Given this list of marker genes ATP1B4, C1orf21, GEMIN5, ZMYND11, RBM12, CCDC88A, CHD4 (chromodomain helicase DNA binding protein 4), JARID2, MCM9, CXCL6, TIPARP (TCDD inducible poly(ADP-ribose) polymerase), PLEKHJ1, PELI2, TEF, INPP4A, FBXO33, PRPF40A, PRKG1, PPP1R14C, GFM1, SETD7, ABTB2, C2CD2, WNK3, TNFRSF11B, PCYOX1, SENP5, CNOT2, MOB1B, ZCCHC14, CBX6, MAP10, DMD, PARP11, STYX, SMG7 (NCBI Gene Id 9887), PRKACB, MANSC1, C11orf58, RIC1, MYO16, GAB1, RTF1, CERS3, SLC25A36, PUM2, ZNF704, NMNAT3, MED14, MLLT3, VCF2, TEAD3, LIMCH1, FYB2, PPP2R1B, RBBP4, SNX2, LRRC37B, NRAS, CDK14, SMARCE1, TOX, KRTAP3-2, E2F6, SMOC1, ZEB2 (NCBI Gene Id 9839), EID2, MYCBP, AP1AR, ZFHX4 (zinc finger homeobox 4), RGS7BP, ABI2, KIAA0319, TMEM131, CCNA2, RGMB, GAN, PAWR, C1QTNF9, ANKRA2, PPP1R12A, ARFGEF3, AJUBA, MPRIP, RORA, USP46, NAA35, HIRA, NRCAM, RETREG2, CBLL1, SLC25A21, FOXO1, TMEM167A (NCBI Gene Id 153339), JMY, PIP5K1A, ZNF217, GPRC5B (G protein-coupled receptor class C group 5 member B), SETD2, ANGEL2, GSE1, USP3, NUAK1, FHIP1A, IGFBP5, EPB41L3, MGARP, PJA1, IKZF1, GLIPR1, TNFSF11, LDLRAD1, MITF, LRATD1, SENP3, NUMB, CHRM3, TBX3, COBLL1, POU2AF1 (POU class 2 homeobox associating factor 1), TAPT1, DACH1, GABRB1, FUBP3 (NCBI Gene Id 8939), WTAP, GPR82, DNMT3B, RMI1, DCUN1D4, RPS20, PCLO, ZNF700, ASCL1, FOXN3, PCBP2, UBL3, FBXO41, KRCC1 (lysine rich coiled-coil 1), RETSAT, CTNNA3, LSM11, SENP6, ERO1B, MAPK8, CDS2, ACER2, MAST4, CNTN5, SOHLH2, PPARA, TM4SF20, ING3, MTCL2, MPC1, PRKD3, RNF182, PAPSS1, WNT5A, NUDT21, HIPK1, CHIC1, ZDHHC22, PALM2AKAP2, TBC1D8B, SUSD4, ZBTB43, CADM2, PDZD8, PPP1R1C, BTF3L4, MTERF4, HOXB7, MYEF2, SDR16C5, EPHA5, BACH2 (NCBI Gene Id 653980), ARL8B, EXTL2, SLC16A7, KCNB1, CHN2, ZDHHC21, PTBP3, GRM6, NBN, FUNDC2, TM9SF3, TAF7L, CNOT7, ARAP3, ATG4C, CNOT9, MSL3, SSB, TMEM87A, DDX6, EIF5A, RASA2, ZMYM2, SH3RF1, PPP4R1, TMEM63B, IRF6, PIM2, RFX5, TMCO3, BIRC6, NR3C1, SKIL, CYLD, JADE2, KMT2A, ZBTB10, CALCRL, RNF185, PELI1, LDLRAD3, C18orf54, PNN, ARID1A, NAV1, CMPK2, ZCCHC2, SP3, PARD6G, EPN2, KLHL15, SORBS2, RPE65, ZNF830, TENM1 (NCBI Gene Id 10405), SNRK (NCBI Gene Id 87229), SUFU, KLHDC10, NIN, MYCT1, OSGEP, BIRC5, AAK1, AKAP11, UGDH, TRAPPC13, BAHCC1, RIOK1, YWHAE, PGRMC1, ITPRID2, TNRC6B, TBR1, DISC1, CSNK2B, KLHL26, AFG3L2, PPP3R1, C1QTNF9B, AEBP2, BRWD1, KLHDC2, CCND2, FZD3, IRX2, ZNF385C, TMEM263, KLHL20, CLOCK, GRM5, NAALADL2, SCAI, TFAP2C, RPS6KA6, ANKRD28, ZMAT3, ABHD17B, RUNX2, NRIP3 (nuclear receptor interacting protein 3), RICTOR, ROBO1, IL1RAP (NCBI Gene Id 3556), FBN2, OTUD1 (NCBI Gene Id 220213), ZIC4, CIPC, HDAC9, RFX3 (regulatory factor X3), KDM2A, TSTD2, EID1, NUDT10, PABPC4, ACBD3, ONECUT2, DDHD2, TLR2, DNAJB14, FBXL3, SEPTIN2, SSH1, AGTPBP1, BMPR1A, RASSF3 (Ras association domain family member 3), HOXC8, CDC14B, MAL2, GRPEL2, SLC36A3, LAMP2, DPY19L1, ARHGAP32, TLCD4, HEG1, IGFBP7, AGTR2, TMEM170B, PREX2, PAPOLG, JUND, ETV5, BNC2, HIPK2, PLCB1, KLHL28, AK1, FAM210B, SERBP1, OSBPL11, CBX5, GNB2, ATM, TBC1D23, SMARCC1, CTDSPL2, FNBP1L, AGO2, WDR43, KIF1B, YWHAZ, NEXMIF, WWC2, GUCY1A2, TRMT10A, PIM1, CITED2, TMEM33, PDS5A, CREBBP, CDYL2, TMX3, ZNF44, DLX3, NEK1, CCDC102A, MBNL2, MAMLD1, RGMA, ATAD1, UBR2, PIAS1, REEP3, UNC5D, NDUFAF4, FAM171B, MSANTD3, TMEM209, IDE, RCOR3 (NCBI Gene Id 55758), FAM169A, TBCEL, TASOR2, VAPA, KIAA0586, CBFB, BMP1, PRKAR2B, ABCD3, JAG1, MIER3, MOB4, RNF169, NIPBL, ERI1, NCAM2, PMS2, NCBP3, LARP4, UBE2D2 (ubiquitin conjugating enzyme E2 D2), GLCE, WASF3, SGIP1, ERBB4, CRISPLD1, ANKRD17, LMNA, OGT, EBPL, HNRNPA3, ARL5A, FAM168A, MBTD1 (NCBI Gene Id 54799), UBE2G1, CHSY1, ELOC, GTF3C4, HSPA14, COG6, MAP4K3, LTN1, ARHGAP28, MFSD14B, AFF4, PRDM1, GPR180, AGPAT1, TIMP3, SASH1, CARF, LCLAT1, CLDN8, MIB1, ZBTB39, USP24, KIF26A, MACF1, FAM222B, RPS6KA2, DDX17, ZNF512, FAM124B, TERF1 (telomeric repeat binding factor 1), C6orf62, WDR89, FGD4, TAX1BP1, RNFT1, RUNDC3B, KRAS, MARCHF1, GLIS1, RBMS3, ERMP1, LRRC47, ARMH4, CPSF6, SEMA6A, RBM46, CTTN, PBX1, RABGAP1, VASP, GABRG1, MAP3K2, SETBP1, HSPE1-MOB4 (HSPE1-MOB4 readthrough), BBS12, ZNF805, TNRC6C, GABPA, USP38, PTPN11 (protein tyrosine phosphatase non-receptor type 11), KLF11, GABRA4, YPEL1, TTC28, MBNL1, ZFAND5, TP53BP1, ELN, MDM4, POC1B-GALNT4, C5orf24, CPNE4, ZBTB34, KMT2C, SOX21, CSNK2A1, GALK2 (NCBI Gene Id 2585), GRIK3, CDC42BPA, SMC6, HTATSF1, NUFIP2, SMAD5, EPHA7, TWSG1, SWAP70, SORCS3, MET (NCBI Gene Id 4233), PNISR, GALNT4, BEND4, SGO2, TBL1XR1, RET, PGM2L1, PAPOLA, RAB33B, MED1, DIS3L2, PTPRZ1, PSD3, CDK12, SAMD8, EIF4E3, TMEM106B, ZBTB21, PPARGC1A, KDM7A, OPRM1, TRPC3, ZNF706 (zinc finger protein 706), SAMD13, TMED10, RB1CC1, ATP6V0A2, DPP10, RNF38, RAG1, CCR1, SLC39A14, DCBLD2, HS2ST1, DDX5, NCL, SYNCRIP, BTBD10, TTC14, FBXO22, CYCS, RIMS2, STK38L, KAT2B, ZC3H12C (zinc finger CCCH-type containing 12C), ZBTB20, FOXN2, TMEM161B, CDK17, ELMOD2, CREB1, ATP2B4, RPS3, PPP4R2, SERP2, PARP12, ZMYM5, PER3, BCL11B, PSPC1, AGPAT3, GOLIM4, here is a description of the gene set: Genes predicted to be targets of miRBase v22 microRNA hsa-miR-548aa, hsa-miR-548ap-3p, hsa-miR-548t-3p in miRDB v6.0 with MirTarget v4 prediction scores > 80 (high confidence targets). studied in species Homo sapiens from publication Chen Y, Wang X (PMID 31504780) Human Gene Set: MIR548AA_MIR548AP_3P_MIR548T_3P